The following is a description of a gene set: Binding to a POU domain of a protein. The POU domain is a bipartite DNA binding domain composed of two subunits separated by a non-conserved region of 15-55 amino acids; it is found in several eukaryotic transcription factors. Mouse Gene Set: GOMF_POU_DOMAIN_BINDING studied in species Mus musculus, and this is the list of marker genes: Pou5f1, Pou2af3, Ar, Nfkbiz, Pou2af1, Pou2af2